Given this list of marker genes BCKDHB, DBT, BCKDHA, here is a description of the gene set: species: Homo sapiens Reactome Pathway: Loss-of-function mutations in BCKDHA or BCKDHB cause MSUD Mutations in either of the protein subunits of the E1 decarboxylase subcomplex of BCKDH are associated with Maple Syrup Urine Disease 1 (MSUD1).<br>Mutations of residues in BCKDHA that participate in subunit associations or that form part of the hydrophobic core destabilize the overall assembly of BCKDH and are associated with classic Maple Syrup Urine Disease 1A. Mutations of BCKDHA with less drastic effects on structural stability of the overall BCKDH complex are generally associated with intermediate or intermittent forms of MSUD, and are not annotated in this pathway<br><br>Mutations in BCKDHB appear to be causative in 35% of MSUD cases. Classic Maple Syrup Disease 1B is associated with severe loss-of-function mutations in BCKDHB that destabilize the protein interaction interfaces and compromise structural integrity of the complex. Less detrimental mutations in BCKDHB are not annotated in this pathway and are generally associated with intermediate or intermittent forms of MSUD. part of: Maple Syrup Urine Disease